The following is a description of a gene set: from publication Cipolletta D, Feuerer M, Li A, Kamei N, Lee J, Shoelson SE, Benoist C, Mathis D (PMID 22722857) We identified Pparg as a major orchestrator of the phenotype of adipose-tissue resident regulatory T cells (VAT Tregs). To establish the role of Pparg in shaping the VAT Tregs gene profile and cell dynamics, Tregs from lymph nodes and visceral adipose tissue of mice sufficient and deficient of Pparg expression in Tregs were double sorted for microarray analysis. Genes down-regulated in lymph node from aged mice: T reg versus T conv. Human Gene Set: GSE37532_TREG_VS_TCONV_CD4_TCELL_FROM_LN_DN studied in species Homo sapiens, and this is the list of marker genes: BCOR, CRTC2, BCL2, HLA-DRB1, CASP1, SYS1, EXOSC7, NME1, NDUFA7, BTG3, MST1, IRGM, KLF12, TAMALIN, PLK3, CLN5, POLR1A, STAP1, PPAN, HTRA2, CRLF2, IFNLR1, RFX5, GLIPR1, MAP3K8, SLC2A3, IQSEC1, BEND5, NLRC5, TRMT61A, C8orf76, RHOF, FTL, AKAP5, DENND1C, EEF1AKMT1, NOC2L, ETV6, NOP2, IKBKE, CHD1L, HLA-B, EEF1E1, AEBP2, FANCA, RAB35, CTSS, DENND5B, EEIG1, STING1, ADAMTS6, ERP44, METTL23, GPATCH4, STX11, KCNAB2, SELL, ATP5MC1, LTA, WDR75, ICAM1, NDUFA3, TBX21, GATD3, PSME1, SIGMAR1, CIITA, LAP3, LIPT2 (NCBI Gene Id 650826), MYL9, RAP1GDS1, ARHGAP24, MACIR, PLAGL2 (PLAG1 like zinc finger 2), NFIL3, DENND11, KCTD1, SLC10A3, NAB1, CHCHD4, SRI, KYNU, TBL3 (NCBI Gene Id 10607), FAM167A, PCNX3, QTRT2, MTHFD1L, SURF2, PPP1R12C, GSTT2, IL2RG, MAP3K1, TAF4B, STRADB, MRPL24, DERL3, STK10, NAAA, HEXB, RP2, ATP6V0E1, TM2D3, GSN, UBXN2A, BID (BH3 interacting domain death agonist), SDHAF1, NFKBIA, MAP2K1, INSIG1, NSUN2, CASP6, SLC20A1, LY86, GIMAP7, SLC19A1, CACNA1D, MGAT5, ZNF579, NOLC1, POLR3E, HSD17B11, PTPN6, ZMIZ2, ABCC4, CPSF3, BIRC2, KAT2A, S100A11, TBC1D14, LCK, GRAMD2B, PREX1, PHPT1, CYTH4, SHMT1, TSR1 (TSR1 ribosome maturation factor), COQ8A (NCBI Gene Id 56997), PSMB10, NFKBIZ, TMC6, FOXJ2, CMTM3, MIF4GD, SEMA7A, MORN1, LAMP2, PIGY, M6PR, ACO1, CALR, UTP15, RASSF5, NR4A1, PCED1B, PARM1, ZFP36L1, DUS3L, LRRC42, SLC2A6, RRBP1, PSMG2, TMA16, ARID5A, DAD1, PLBD1 (phospholipase B domain containing 1), SNHG17, PPIB, CLN3, USE1, TFRC, NXPE3, GRIPAP1, ALKBH7, TRNT1, PARP3, EPRS1, TUFT1, CLPTM1L, TMEM41A, STAT6, FXYD5, LYAR, RAB30, PAG1, STOML2, FFAR2, TVP23B, CYB5R3, TANK (TRAF family member associated NFKB activator), RAD17, CCDC134, TMEM208, ARAP1, STIM1, DNAJB5, TRAPPC2L, THOP1, PPP1R14B, RNF138, PTPRE